The following is a description of a gene set: species: Homo sapiens Human Gene Set: GOBP_POSITIVE_REGULATION_OF_MONOCYTE_EXTRAVASATION Any process that activates or increases the frequency, rate or extent of monocyte extravasation., and this is the list of marker genes: CD47, CCR2, AGER (NCBI Gene Id 177), JAM3, PDGFD